The following is a description of a gene set: Genes predicted to be targets of miRBase v22 microRNA hsa-miR-1294 in miRDB v6.0 with MirTarget v4 prediction scores > 80 (high confidence targets). from publication Chen Y, Wang X (PMID 31504780) Human Gene Set: MIR1294 species: Homo sapiens, and this is the list of marker genes: KCTD21, USP12, DDX19B, RGP1, NPEPL1, MYH9, BRCC3, ZNF689, CTBP2, SEC24C, CYB561D1, TENM2, CSNK2A2, C1GALT1 (NCBI Gene Id 56913), RBFOX2, OAS2, LRCH2, DMD, C14orf28, TCF7L1, IMPG2, PBX1, ATG16L1, CUX1, TGFBR1, CD164, PALD1, SART3 (NCBI Gene Id 9733), DVL3, COL4A1, ADAMTS6, AMBRA1, SGCG, BBX, INPP5A, TMEM144, KRT78, ARRB2, ABCA1, ST7L, TEAD1, TMOD2, ARHGAP28, TP53INP1, CHIC1, HSPA14, CXCL8, SKIL, FZD3, CFL2, LUC7L3, TECPR2, SPOCK3, SPTBN4 (NCBI Gene Id 80322), ZNF714, RDX, GNS, MTOR, NCR3LG1, EXT1, COL27A1, SERF2, YOD1, ADRB1, SCYL2, DLGAP4, KLHDC8B, CCND2, ZNF782, GPX7, KCTD17, FIGN, MSR1, ZNF33B, TMEM26, TRMT13, YIPF1, PABIR1, FNDC3B, TMPRSS11B, NOP14, UBE3D, CLCN5, BRWD1 (bromodomain and WD repeat domain containing 1), CDHR1, RCN2, KRT20, MYCL, TAF9B, ADAMTS1, ADAMTS8, RAB3GAP2, FARP1, SYT4, DDX19A, PIM1, PDPR, PARM1, PAPPA, IGF1R, RNF126, CCNJL, DIABLO, CRK, SEC14L1, SURF4 (surfeit 4), PIP4K2C, MEAF6, C6orf132, SEC24A, GXYLT1, RBMS2, FZD4, SLC31A2, PTP4A2, ZNF835, MAN2A2, LIMD1, ARHGEF10L, STARD3NL, IARS1, SULF2, KLHL24, DPAGT1, VPS9D1, BNC2 (NCBI Gene Id 54796), PRKAA2, NOL4L, PURB, C8orf58, CSRNP3, AGO1, MLX, PRRX1, RGS6 (NCBI Gene Id 9628), CBX5, MYC, THRSP, PPARA (NCBI Gene Id 84730), HAS2, ZSWIM4, COL4A6, SCN4B, SUCLG2, TRIB2, KCNQ4, PTPRG, MACO1, KIAA0930, CLDN12, TMEM178B, IGSF1, AGO4, RNF170, RAB18, SPTSSB, CDC34, ENPP1, AREL1, CELF2, ZNF644